Given this list of marker genes Mutyh, Mpg, Mbd4, Ogg1, Tdg, Apex1, Nthl1, here is a description of the gene set: This event has been computationally inferred from an event that has been demonstrated in another species.<p>The inference is based on the homology mapping from PANTHER. Briefly, reactions for which all involved PhysicalEntities (in input, output and catalyst) have a mapped orthologue/paralogue (for complexes at least 75% of components must have a mapping) are inferred to the other species. part of: Resolution of Abasic Sites (AP sites) electronically inferred by orthology from the curated human pathway species: Mus musculus Reactome Pathway: Displacement of DNA glycosylase by APEX1